Given this list of marker genes Banf1, Chmp2b, Chmp1b2, Nsfl1c, Reep3, Chmp6, Reep4, Vps4b, Chmp5, Vps4a, Ubxn2a, Ankle2, Ubxn2b, Brox, Chmp2a, Chmp4c, Chmp4b, Chmp7, Spast, Chmp3, Chmp1a, Chmp1b, here is a description of the gene set: The reformation of the nuclear membranes following their breakdown in the context of a normal process. Mouse Gene Set: GOBP_NUCLEAR_MEMBRANE_REASSEMBLY studied in species Mus musculus